The following is a description of a gene set: Genes down-regulated in comparison of healthy B cells versus healthy myeloid cells. Human Gene Set: GSE10325_BCELL_VS_MYELOID_DN from publication Hutcheson J, Scatizzi JC, Siddiqui AM, Haines GK 3rd, Wu T, Li QZ, Davis LS, Mohan C, Perlman H (PMID 18275831) studied in species Homo sapiens Gene expression profile studies have identified an interferon signature in whole blood or mononuclear cell samples from patients with systemic lupus erythematosus. This study was designed to determine whether specific lymphocyte and myeloid subsets freshly isolated from the blood of systemic lupus erythematosus patients demonstrated unique gene expression profiles compared to subsets isolated from healthy controls., and this is the list of marker genes: CCR1, LST1, CD93, CSF1R, BLVRB, CYBRD1, GNA15 (G protein subunit alpha 15), SIRPA, DUSP6, CD163, PDK3, RNPEP, C3AR1, LILRA3, MTMR11, SRGN, SLC7A7, LILRB2, S100A4, PAK1, HMOX1, SUOX, LAMP2 (lysosomal associated membrane protein 2), MS4A6A, LILRA2, TLR5, RAB27A, P2RY13, PTGDR2, HTRA1, CEBPD, ADGRE3, CFD, PILRA, SECTM1, ADA2, CLEC10A, FGL2, NCF2, PRKCD, CARD9, TNFRSF1B, CLEC4A, NFE2, CMKLR1, PELI2, LILRB3, GOLM1, LILRA1, PTPRE, TGFBI, SH2B3, ADGRE2, VENTX, GALC, OASL, ADORA2B, ZDHHC7, PLXNB2, PSAP, FCGR1BP, SLC43A3, CDK2AP1, ALDH2, LGALS3, QPRT, KIAA0513, CXCR2, TCF7L2, TKT, MAPKAPK3, MEGF9, ICAM4, ICAM1, GAS7, CSTA, QPCT, RPH3A, PTGIR, MYO1F, VNN1, CRISPLD2, CALML4, NLRP3, BLVRA, SNX27, BID, COTL1, LMO2, RIN2, CLIC2, IMPA2, ACTG1, DHRS9, CYP1B1, VPS37C, AQP9, SLC31A2, NPL, C2CD2L, CFP, TRIM8, CAMK1, SULT1A1, PLXND1, FTH1P5, DRAM1, MYCL, NAAA, CTSL, FOS, SMCO4, GAB2, TBC1D8, PLBD1, TM6SF1, FCGRT, FBP1, PLAUR, THEMIS2, CCR5, SERPINA1, RRAGD, TNFSF13, NAGA, TNFRSF10C, CASP1, CTBP2, ADM, CD300A, CCR2 (NCBI Gene Id 90262), MICAL2, ANXA5, RGS2, FCER1A, LGALS2, MPP1, CD302, CCDC88A, AIF1, CTSB, RXRA, KCNMB1, OSBPL1A, C15orf39, FAR2, CPD, IGSF6, TLR2, IL1RN, TNFAIP2, DUSP1, NACC2, CDA, HBEGF, PHC2, MSRB2 (NCBI Gene Id 51648), RNF130, MYD88, GRAMD1B, ROGDI, CPVL, COQ2, ADGRE1, SLC11A1, NOD2, C5AR1, TESC, TNFRSF8, SAT1, PGAM1, KCTD12, HSBP1, RAB32, CTSA, RAB5IF, HEXB, APOBEC3A (apolipoprotein B mRNA editing enzyme catalytic subunit 3A), OAZ2, CYFIP1, CEBPA, CLEC7A, GNS, KLF4, RTN3, SASH1, FCGR2A, CD244, DAPK1, SCO2, CEBPB, MAFB, ASGR1, HK3, CDKN1C, TBXAS1, MSRB1, FPR1, SLC27A3, AOAH